The following is a description of a gene set: Human Gene Set: GOBP_WATER_SOLUBLE_VITAMIN_METABOLIC_PROCESS species: Homo sapiens The chemical reactions and pathways involving any of a diverse group of vitamins that are soluble in water., and this is the list of marker genes: SLC25A42 (NCBI Gene Id 57831), MMAB, DHFRP1, SLC2A1, ALPL, MCCC1, PDXK, ALDH1L2, PANK2 (pantothenate kinase 2), CUBN, AMN, SLC25A32, RFK (riboflavin kinase), SELENON, PDXP, SHMT1, PNPO, DHFR, HLCS, TKTL1, SLC52A2, MMADHC, MTHFS, SLC19A3, CLYBL, SLC52A1, MTHFD2L, SLC2A3, SLC19A2, TPK1, VNN1, VNN2, SLC25A16, MMAA, GCLC, SLC52A3, ACP3, MTHFD2, SLC46A1, MTHFD1, ERO1A, MMACHC, BTD, FLAD1, THTPA, FOLR1, SLC23A1, PLPBP, SLC25A19 (NCBI Gene Id 60386), SLC19A1, DHFR2 (dihydrofolate reductase 2), AASDHPPT, SLC5A6, ATP1A2, NNMT, GSTO1, PSAT1, PM20D2, PANK4, SLC23A2, GSTO2, FPGS, ABCD4, CLSTN3, MTR, MTRR